The following is a description of a gene set: species: Mus musculus Mouse Gene Set: MORI_SMALL_PRE_BII_LYMPHOCYTE_UP Up-regulated genes in the B lymphocyte developmental signature, based on expression profiling of lymphomas from the Emu-myc transgenic mice: the Small Pre-BII stage. The Emu-myc transgenic mouse has provided a valuable model for the study of B-cell lymphoma. Making use of gene expression analysis and, in particular, expression signatures of cell signaling pathway activation, we now show that several forms of B lymphoma can be identified in the Emu-myc mice associated with time of tumor onset. Furthermore, one form of Emu-myc tumor with pre-B character is shown to resemble human Burkitt lymphoma, whereas others exhibit more differentiated B-cell characteristics and show similarity with human diffuse large B-cell lymphoma in the pattern of gene expression, as well as oncogenic pathway activation. Importantly, we show that signatures of oncogenic pathway activity provide further dissection of the spectrum of diffuse large B-cell lymphoma, identifying a subset of patients who have very poor prognosis and could benefit from more aggressive or novel therapeutic strategies. Taken together, these studies provide insight into the complexity of the oncogenic process and a novel strategy for dissecting the heterogeneity of B lymphoma. from publication Mori S, Rempel RE, Chang JT, Yao G, Lagoo AS, Potti A, Bild A, Nevins JR (PMID 18922927), and this is the list of marker genes: Spin1, Ncaph2, Arl5a, Fcrla, Rbm17, Fgf12, Uba52, Erp29, Dusp11, Slc1a5, Ttc7b, Pim2, Rb1, Dbnl, Pramel6, Apobec1, Skap2, Tcf12, Psapl1, Cyb5r4, Fdx2, Eps8, Ackr3, Slc25a51, Rhoj, Reln, Igsf10, Sec11c, Prm1, Marcks, Cd1d1, Pou2af1, Polm, B4galt1, Xpnpep1, Myl4, Txk, Frat2, Btg2, Adra2a, Tcp10a, Csf2, Tax1bp3, Klhdc2, Hspa2, Il12a, Wtap, Slc11a2, Cerk, Ech1, Srp14, Rgs2, Psme4, Akirin1, Dtna, Prrg2, Trim11, Eya3, Adam10, Herpud1, Spg21 (SPG21, maspardin), Gas7, Emid1, Clock, Epha3, Desi1, Ccng2, Ptger2, Selenow, C1galt1 (NCBI Gene Id 94192), Pafah1b3, Ache, Cacng1, Slain1, Irf4, Myo5a, Ptprb, Acss1